Given this list of marker genes Mllt3, Nav1, Ifit3b, Iqsec3, Zfp111, Srgap2 (NCBI Gene Id 98351), Mapk7, Tspyl4, Kirrel3, Scn3a, Arsk, Clock, Ifi44l, Ubn2, Gpr183, Arhgef9, Smim1, Slit2, Arpin, Map1a, Efnb2, Mrps24, Neu1, Scamp1, Ubtfl1, Tafa5 (TAFA chemokine like family member 5), Fnbp4, Ei24, Tnrc6b, Rnf11, Memo1, Reps2, Prr23a4 (proline rich 23A, member 4), Dnajc16, Adgrv1, Dlst, Ttll7, Rap1b, Gadd45gip1, Tcf12, Mettl2, Tmem50b, Aph1a, Nos3, Lrrc18 (leucine rich repeat containing 18), Ocln, Mphosph6, Atf6, Pax3, Kera, Cyp24a1, Chrm2, Cbln2, Amfr, Hapln1 (NCBI Gene Id 12950), here is a description of the gene set: from publication Chen Y, Wang X (PMID 31504780) studied in species Mus musculus Mouse Gene Set: MIR_3081_5P Genes predicted to be targets of miRBase v22 microRNA mmu_miR_3081_5p in miRDB v6.0 with MirTarget v4 prediction scores > 80 (high confidence targets).